Given this list of marker genes EXOSC9, SKIC2, EXOSC5, EXOSC3, EXOSC1, EXOSC2, SKIC3, EXOSC7, EXOSC4, EXOSC8, DCPS, SKIC8, HBS1L, DIS3, EXOSC6, NT5C3B, here is a description of the gene set: part of: Deadenylation-dependent mRNA decay species: Homo sapiens Reactome Pathway: mRNA decay by 3' to 5' exoribonuclease The degradation of mRNA from 3' to 5' occurs in two steps. First, the exosome exoribonuclease complex binds the 3' end of the oligoadenylated mRNA and hydrolyzes it from 3' to 5', yielding ribonucleotides having 5'-monophosphates, until a capped oligoribonucleotide remains. Second, the scavenging decapping enzyme DCPS hydrolyzes the 7-methylguanosine cap.